Given this list of marker genes Myl6b, Nexn, Pdlim3, Plec, Dag1, Csrp1, Tcap, Myh11, Myl6, Mybpc3, Synm, Csrp2, Jph1, Myl1, Dmd, Csrp3, Capn3 (calpain 3), Mylpf, Krt19, Myl2, Ttn, here is a description of the gene set: Mouse Gene Set: GOMF_STRUCTURAL_CONSTITUENT_OF_MUSCLE The action of a molecule that contributes to the structural integrity of a muscle fiber. species: Mus musculus